Given this list of marker genes Nkx3-1, Lta, Nop53, Parp2, Fmn2, Pik3cb, Rock2, Postn (NCBI Gene Id 99708), Mir365-1, Pld2, Angptl4 (angiopoietin-like 4), Pgf, Tsc1, Vegfb, Ubqln1, Abcb1a, Bnip3, Fas, Mir199a-2, Alas2, Itga2, Smad3, Vegfd, Ager, Atm, Cryab, Col1a1, Chrna4, Pck1, Sdhd, mt-Nd1, Ryr1, Pml, Atp6v1a, Adam8, Grin2b, Bmyc, Nr4a2, Cr1l, Flt1, B3gat1, Ptgis, Mir133b, Mir146b, Commd1, Nppc, Ajuba, Aqp3, Atp1b1 (NCBI Gene Id 11931), Ndufs4, Tbl2, Dio3, Prl4a1, Ep300, Mir126a, Vegfc, Dpm1, Tfrc, Sox2, mt-Co2, Phb2, Mir30e, Slc2a4, Drd2, Ang, Mtor, Cysltr1, Sod2, Zfp36l1, Slc29a1, Cat, Hilpda, Gucy1a1, Pink1, Hif3a, Kcna5, Mir103-1, Plau, Ccr2, Prkce, Myocd, Gnb1, Mir762, Cpeb2, Nfatc3, Ddr2, mt-Co1, Polb, Hk2, Tgfb3, Cybb, Aifm1, Mir208a, Alad, Mir20b, Npepps, Mir365-2, Hyou1, Hp1bp3, Daxx, Akt1, Alkbh5, Gucy1b1, Zeb2, Acvr2a, Fam162a, Mir668, Fndc1, Atp6ap1, Egr1, Mir127, Adam15, Cd38, Car9, Mmp2, Kdr, Acaa2, Cited2, Tacc3, Pou4f2, Plekhn1, Epha4, Mief1, Ptk2b, Ada, Atg7, Rwdd3, Camk2g, Atp6v1g1, Mir214, Cpeb4, Mir499 (microRNA 499), Cav3, Ascl2, Tfam, Mir16-2, Cysltr2, Slc6a4, Mir221, Tnf, Slc8a1, Ccdc115, Bmp2, Suv39h2, Mir17, Gucy1a2, Egln2, Mir150, Eno1, Clca1, Txn2, Tmbim6, Mir132 (microRNA 132), Tgfb1, Mirlet7b, Trem2, Eif4ebp1, Itpr2, Mir155, Loxl2, Raf1, Penk (NCBI Gene Id 18619), Prmt2, Nos2, Mir15b, Pparg, Mir34a, Dnmt3a, Th, Casp1, Mb, Ucn3, Rora, Tert, Nono, Wdr83, Pdk3, Cdkn1b, Mir30b, Kcnk3, Adsl, Camk2d, Aqp1, Mdm2, Kcnma1, Foxo1, Mir133a-1, Arnt, Polr2a, Mst1, Stc2, Mir335, Lif, Ppard (peroxisome proliferator activator receptor delta), Uts2, Agtr1b, Lonp1, Vegfa, Xrcc1, Ak4, Tek, Ang2, Mir222, Mir140, Mir133a-2, Il3, Ucp3, Ndrg1, Mir711, Tmem199, Usf1, Mapk8, Hmox2, Pten, mt-Nd4, Mir199a-1, Scn2a (NCBI Gene Id 241424), Pin1rt1, Mir15a, Mir497, Angpt2, Drd1, Becn1, Map1lc3a, Casp9, Cryaa, Lmna, Slc2a8, Atp6v0d1, Cav1, Dram1, Ece1, P4hb, Zfas1, Kcnj11, Notch1, Oprd1, Lep, Ptgs2, Tsc2, Sod3, Tm9sf4, Ptpn1, Cyp1a1, Mstn, Col6a1, Pygm, Kcnk2, Acvrl1, Aldh3a1, Casr, Rtn4, P2rx2 (purinergic receptor P2X, ligand-gated ion channel, 2), Fundc1, Scfd1, Plat, Usp19, Pin1, Hsp90b1 (heat shock protein 90, beta (Grp94), member 1), Mecp2, Ace, mt-Atp6, Ccna2, Edn1, F7, Ciao3, Mir31, Angpt4, Vasn, Cbfa2t3, Hmox1, Comt, Fos, Mir705, Higd1c (NCBI Gene Id 380975), Adm, Slc1a1, Crhr1, Ryr2, Brip1, Mir491, Smad4, Dpp4, Fosl2, Ado, P2rx3, Sirt4, mt-Cytb, Fzd4, Itpr1, Sox4, Chrnb2, Lct, Vhl, Ndufs2, Limd1, Bbc3, Inhba, Stat3, Mir483, Reg1, Ercc3, Hif1a, Arnt2, Il1a, Apaf1, Mir10a, Rptor, Mir107, Sirt1, Acot2, Slc8a3, Foxo3, Mirlet7d, Atf4, Abat, Mir574, Il18 (interleukin 18), Gucy1b2, Adam17, Nppb, Rest, Nf1, Sirt2, Pgk1, Dnm1l, Slc2a1, Ndp, Suv39h1, Ercc2, Myod1, Slc9a1, Ngb, Mir26b, Ang6, Mirlet7g, Ndnf, Cd24a, Cbl, Ucp2, Ireb2, Chchd2, Ero1a, Kcnj8, Prl8a2, Atp6v0a2, Mmp14, Stc1, mt-Nd5, Pdk1, Cpeb1, Mir207, Gad2, Mir106a (microRNA 106a), Nox1, Egln1, Ddah1, Agtrap, Ang5, Mlst8, Mirlet7e, Ddit4, Rad21, Cfh, Mir146, Slc4a1, Vldlr, Bad, Trh, Pick1, Slc39a12 (NCBI Gene Id 99291), Cldn3, Nol3, Abcc9, Mir379, Mir327, Mir142, Atf2, Mt3, Nfe2l2, Endog, Chchd2-ps, Gngt1, Eno1b, Mir223, Egln3, Slc7a5, Birc2, Ednra, Mir10b, Carlr, Wtip, Mir30d, Bcl2, Adipoq, Adrb2, Trpv4 (transient receptor potential cation channel, subfamily V, member 4), Hsd11b2, Mir874 (NCBI Gene Id 100124491), Myc, Ccl2, Map2k1, Fabp1, Pdcd10, Scap, Capn2, Ang4, Twist1, Gata6, Oxtr, Mgarp, Casp3, Eng, Kdm6a, Plod1, Tgfb2, Mir199b, Ppara, Pak1, Cygb, Srf, Cbs, Rgcc, Mir204, Bnip3l, Cdkn1a, Mir92b, Epas1, Cpt1a, Higd1a, Src, Ptprd, Mir16-1, Adora1, Lpar1 (lysophosphatidic acid receptor 1), Ogt, Tigar, Sfrp1, Mir21a, Trp53, Prkaa1, Kcnd2, Pdlim1, Epo, Eef2k, here is a description of the gene set: Any process that results in a change in state or activity of a cell or an organism (in terms of movement, secretion, enzyme production, gene expression, etc.) as a result of a stimulus reflecting the presence, absence, or concentration of oxygen. species: Mus musculus Mouse Gene Set: GOBP_RESPONSE_TO_OXYGEN_LEVELS